Given this list of marker genes RAB13, LAMA4, ACKR3, MAPK14, ANAPC1, ANXA1, COL1A2, NR3C1, MITF, RALGDS, TFAP2A, ABL1, MYLK, TGFBR3, PTGIS, TPM2, ACO1, HNMT, ACTA2, ACTG1, TFAP4, TIMP3, RBMS1, NFIC, TENT5A (NCBI Gene Id 55603), UBL4A, SERPINE1, NR2F2, ID2, XPC, LOX, CCND1 (cyclin D1), ADH1B, ADRA2A, TNNI3, IL6ST, POSTN, USP4, ACVR2A, FLNA, HSD17B2, ZFP36L1, MN1, AR, AKR1C1, SGCG, CXCL12, THBS1, TPM4, TRAM2, EFEMP1, CDH11, PABPC1, DDIT4, ZNF521, BCL2 (NCBI Gene Id 596), CFD, HIVEP2, IGFBP5, PAFAH1B1, PTPN13, COL5A2, LAMB2, CEBPD, CRHBP, IGFBP2, ANPEP, DDR2 (NCBI Gene Id 4921), MBL2, SERPINB6, ZCCHC9, COL6A2, CYP1B1, IGFBP3, MMP1, THBS2, RUNX1, PDGFRA, TAGLN, IGF2, CNN2, FTL, GPX1, MYH9, ITSN1, GAS1, AHR, ERCC5, ANP32A, TMEM198B, COL1A1, MATK, BMP4, EPO, FGF7, FKBP10, LMNA (lamin A/C), TP53BP1 (tumor protein p53 binding protein 1), IGF1R, WEE1, MARCKS (NCBI Gene Id 4082), FBLN1, PYCR1, ADM, ENG (endoglin), CDC25B, COL3A1, CFHR1, F7, CHN1, C1R, VCAN, APOE (NCBI Gene Id 99), CD151, SULT1E1, TNFRSF1A, AARS1, C7orf50, TCF7L2, here is a description of the gene set: species: Homo sapiens from publication Zhu H, Cong JP, Mamtora G, Gingeras T, Shenk T (PMID 9826724) Mechanistic insights to viral replication and pathogenesis generally have come from the analysis of viral gene products, either by studying their biochemical activities and interactions individually or by creating mutant viruses and analyzing their phenotype. Now it is possible to identify and catalog the host cell genes whose mRNA levels change in response to a pathogen. We have used DNA array technology to monitor the level of approximately 6,600 human mRNAs in uninfected as compared with human cytomegalovirus-infected cells. The level of 258 mRNAs changed by a factor of 4 or more before the onset of viral DNA replication. Several of these mRNAs encode gene products that might play key roles in virus-induced pathogenesis, identifying them as intriguing targets for further study. Human Gene Set: ZHU_CMV_ALL_DN Down-regulated at any timepoint following infection of primary human foreskin fibroblasts with CMV